The following is a description of a gene set: Myogenesis studied in species Homo sapiens Human Gene Set: REACTOME_MYOGENESIS, and this is the list of marker genes: MEF2D, CTNNA2, MYF5, MAP2K6, TCF12, BNIP2, MAPK14, MAPK11, MYOG, MEF2A, CDH4, MEF2B, CDON, CDC42, NTN3, MAPK12, BOC, CTNNB1, TCF3, MYF6, CDH2, TCF4, NEO1, ABL1, MYOD1, SPAG9, CTNNA1, CDH15, MEF2C